Given this list of marker genes GYG2, GYS2, ARSB, SI, GYG1, NAGLU, GYS1, UBB, G6PC1, RPS27A, GBE1, NHLRC1, G6PC3 (NCBI Gene Id 92579), PPP1R3C, DCXR (NCBI Gene Id 51181), ALDOB, IDS, HYAL1, UBC, HGSNAT, SLC37A4, UBA52, GUSB, GALNS, GNS, RPIA, LCT, GAA, SGSH, GLB1, EPM2A, TALDO1, IDUA, KHK, here is a description of the gene set: Reactome Pathway: Diseases of carbohydrate metabolism part of: Diseases of metabolism The processes by which dietary carbohydrate is digested to monosaccharides and these are taken up from the gut lumen into cells where they are oxidized to yield energy or consumed in biosynthetic processes are a central part of human metabolism and defects in them can lead to serious disease. Defects annotated here affect saccharide digestion in the gut lumen, fructose metabolism, and the pentose phosphate pathway. In addition, the defect in glucuronate catabolism that leads to essential pentosuria, a benign phenotype that is one of Garrod's original four inborn errors of metabolism, is annotated. species: Homo sapiens